The following is a description of a gene set: studied in species Mus musculus Mouse Gene Set: GOBP_NEURAL_PRECURSOR_CELL_PROLIFERATION The multiplication or reproduction of neural precursor cells, resulting in the expansion of a cell population. A neural precursor cell is either a nervous system stem cell or a nervous system progenitor cell., and this is the list of marker genes: Ncor2, Gli1, Mapk8, Slc16a2, Adcyap1, Atf5, Gjc2, Ctnnb1, Igf2bp1, Tafa1, Mir574, Kifap3, Drd2, Gnai2, Flna, Ngfr, Rhoa, Disp3 (NCBI Gene Id 631463), Sall1, Ntrk3, Arhgef2, Kif3a, Sirt2, Ell3, Fgfr2, Nfia, Foxg1, Btg2, Kdm2b, Bbs1, Gh, Dct, Pde9a, Gli2, Appl2, Fzd6, Rapgef1, Pcnt, Akna (AT-hook transcription factor), Shoc2, Lrp6, Vsx2, Nf2, Rsu1, Rere, Ctf2, Fgfr1, Zeb2, Afdn, Dbx2, Ngf, Hook3, Bdnf, Ptprz1, Hhip, Fgf13, Slc6a4, Pitx3, Gpr37l1, Shank3, Nbn, Nf1, Lnx2, Fzd3, Cip2a, Hmga2, Ascl1, Nde1 (nudE neurodevelopment protein 1), Gli3, Pax6, Cntnap2, Emx1, Zfp503, Cdh2, Itgb1, Foxo1, Pafah1b1, Mios, Id2, Dll4, Cend1, Dock7, Trnp1, Egf, Trp53, Lef1, Hif1a, Cdon, Cx3cl1, Ift20, Ndufs2, Gbx2, Ift88, Tead3, Cd24a, Ryk, Pou3f3, Ptn, Foxo3, Ilk, Neurod4, Ankrd11, Trf, Wdr47, Pcm1, Zzef1, Bex1, Ctnna1, Tox, Smarca1, Vegfa, Wnt5a, Sbno1, Dagla, Kif14 (NCBI Gene Id 52269), Cep120, Kif1a (kinesin family member 1A), Plxnb2, Dbn1, Prdm4, Igf1, Wnt7b, Spint1, Smo, Smarcd3, Cntnap4, Wnt7a, Lrrk2, Erbb2, Cx3cr1, Nfix, Tgfb1, Insm1 (NCBI Gene Id 53626), Six3, Rpgrip1, Cxcr4, Rab10, Sox10, Sox5, Frs2, Skor2, Lhx2, Disc1, Spint2, Zfp423, Numbl, Wnt3a, Notch1, Trim71, Id4, Rora, Hhex, Melk, Ccr5, Hdac5, Prox1, Dmrta2, Optn, Fgf2, Rassf10, Tacc2, Wnt1, Nrg1, Prl2c2, Kctd13, Arx, Lhx5 (LIM homeobox protein 5), Fgf8, Shcbp1, Numb, Gak, Eml1, Il1b, Kcna1, Wnt2, Shh, Grn, Wdr62, Emx2, Ephb1, Nog, Otp, Mdk, Daglb, Lims2, Zfp335, Adgrg1, Vegfc, Sox2, Mup20, Gng5, Rrm1, Psmg1, Lrp2, Hdac3 (NCBI Gene Id 15183), Nap1l1, Ptbp2, Acsl6, Tacc3, C5ar1, Tacc1, Aspm, Vax1, Pou3f2, Nr2e1, Fabp7, Kctd11, Racgap1, Trim3, Tarbp2, Rarb, Orc3, Dixdc1, Kdm1a, Paupar, Gata2, Nes, Fgfr3, Fzd9, Setd1a, Nfib, Lyn, Lims1 (LIM and senescent cell antigen-like domains 1)